Given this list of marker genes PALB2, RNU4ATAC, FANCM, PIEZO2 (piezo type mechanosensitive ion channel component 2), FANCB, ACTG1, EPG5, NCAPG2 (NCBI Gene Id 54892), TMEM67, CEP290 (NCBI Gene Id 9707), NPHP3, RAD51C, KMT2D (NCBI Gene Id 8085), APRT, LMOD1, TMEM216, FANCD2, HPSE2, CDKL5, VANGL1, TRIM8, RFWD3, SETBP1, PIGN, ERCC4, ARX, SLC22A12, FAM20C, UBE2T, AXIN1, SLC25A22, TCTN1, BCOR, MYLK, HS2ST1, MBTPS2, GPC3, PLEC, CEP55, PIGP, PIGT, RPGRIP1L, SMC3, FANCF, SPINT2 (serine peptidase inhibitor, Kunitz type 2), FANCI, ERCC6, KDM6A, KCTD1, CPT2, XRCC2, FANCA, RPGRIP1, LAMC2, TP63, FOXF1, DYNC2LI1, NAA10, ERCC8, SOS1, LAMA3, TCTN2, FLNA, APC2, GLI1 (GLI family zinc finger 1), MYH11, RAD51, TAF4, PEX6, PRKACA, ZMPSTE24, CSPP1, B3GLCT, PIGQ (phosphatidylinositol glycan anchor biosynthesis class Q), FUZ, KIF14, SCN1B, MED12, RIPK4, ARID1B, LAMB3, ITGA6, DMXL2 (Dmx like 2), GNAO1, RAB23, PSMD12, FANCL, TCTN3, FANCC, NEUROD2, FANCE, TXNDC15, MKS1, TMEM107, SOS2, CHRM3 (cholinergic receptor muscarinic 3), EVC2, ALG9, SIK1, BBS12, EDNRA, RBM8A, FREM2, TMEM237 (NCBI Gene Id 65062), CC2D2A, NSD1, PLD1, TMEM231, LONP1, PRPS1, COL18A1, CCNQ, HNF1B, FANCG, GRIP1, ITGB4, SLC32A1 (solute carrier family 32 member 1), IFT140, ACTB, GATA6, NODAL, GSN, EVC, MAD2L2, GRIN1, B9D2, LHX1 (NCBI Gene Id 3975), CASK, BRCA2, GPC4, LMNA, SLX4, PBX1, SLC6A17, MKKS, B9D1, KCNA1 (NCBI Gene Id 729214), BRIP1 (NCBI Gene Id 83991), ACTG2, GRM7, NDUFAF3, DDB1, GLI3, AQP2, PAK2, SCN2A, PRKACB, MAPRE2, FIBP, TBX18, WFS1, SOX17, PORCN, NADSYN1, PNKP, BRCA1, AVPR2, here is a description of the gene set: A structural abnormality of the ureter. The ureter is the duct by which urine passes from the kidney to the bladder. Human Gene Set: HP_ABNORMAL_URETER_MORPHOLOGY Abnormal ureter morphology species: Homo sapiens